Given this list of marker genes CYP2R1 (NCBI Gene Id 79445), SLC34A3, CLCN5, VDR, IDH1, CYP27B1, here is a description of the gene set: Enlargement of the ankles Human Gene Set: HP_ENLARGEMENT_OF_THE_ANKLES studied in species Homo sapiens